Given this list of marker genes Rbm3, Btg2, Hspa1b, Hspa1a, Fos, Junb, Jun, Tsc22d3, here is a description of the gene set: Genes negatively differentially expressed in cell type: CD4+ T cell upon treatment with cytokine: FasL in mouse lymph nodes in vivo. Cytokines mediate cell-cell communication in the immune system and represent important therapeutic targets. A myriad of studies have highlighted their central role in immune function, yet we lack a global view of the cellular responses of each immune cell type to each cytokine. To address this gap, the authors created the Immune Dictionary, a compendium of single-cell transcriptomic profiles of more than 17 immune cell types in response to each of 86 cytokines (>1,400 cytokine-cell type combinations) in mouse lymph nodes in vivo. A cytokine-centric view of the dictionary revealed that most cytokines induce highly cell-type-specific responses. For example, the inflammatory cytokine interleukin-1β induces distinct gene programmes in almost every cell type. A cell-type-centric view of the dictionary identified more than 66 cytokine-driven cellular polarization states across immune cell types, including previously uncharacterized states such as an interleukin-18-induced polyfunctional natural killer cell state. Mouse Gene Set: CUI_T_CELL_CD4_FASL_RESPONSE_DN from publication Cui A, Huang T, Li S, Ma A, Pérez JL, Sander C, Keskin DB, Wu CJ, Fraenkel E, Hacohen N (PMID 38057668) species: Mus musculus